The following is a description of a gene set: Mouse Gene Set: chr17E1 species: Mus musculus, and this is the list of marker genes: Togaram2, Myom1, Gm9311, Lpin2, Gm30091, Mettl4-ps1, Gm17228, Mir5709, Ypel5, Gm24730, Gm9319, Clip4, Gm49931, Lrrc30, Obox6-ps1, 5031415H12Rik, Lclat1, Gm16519, Gm26510, Gm49866, Pja2, Snord53, Gm22858, Efna5, Gm49894, Gm30420, Gm36252 (NCBI Gene Id 102640102), Gm9288, Lbh, Smchd1, Ndufv2, Akain1, Myl12b, Ptprm, Man2a1, Tmem232, Fbxl17, Lama1, Washc1, Spdya, Txndc2, Fer, 4930583I09Rik, Gm4512, Gm18992, Tmem200c, Gm18138, Gm36594, Gm49865, Gm9300, AU016765, Dlgap1, Dreh, 1600022D10Rik, Rab31, Mir6420, Wdr43, Snord92, 1700016K05Rik, Gm4701, Gm25406, Gm46576, Gm33890 (NCBI Gene Id 102636965), Gm35550, Gm5497, C030034I22Rik, Arhgap28, Gm4705, Gm18521, Gm19183, Gm18738, 4930471L23Rik, Gm49940, Gm6174, Twsg1, Gm49862, A930029G22Rik, Epb41l3, 4930405O22Rik, Gm25344, Myl12a, Gm17891, Gm18070, Alk, Ankrd12, Gm9598 (predicted gene 9598), L3mbtl4, Gm20742, Tgif1, Gm36201, Gm9984, Gm41611, Gm25800, Ndc80, Gm38593, Gm4566, Gm7253, Gm41609, Ralbp1, Gm17921, Gm49870, Ppp4r1, Rab12, Gm9320, Mtcl1, Gm18736, 2410021H03Rik, Zbtb14, Mir1195, Pcare (NCBI Gene Id 225004), Gm36487, Vapa, Trmt61b, Themis3, Gm4561, Emilin2, Gm15974, Gm26963, A730049N16Rik, Gm4518, Gm4707, Gm18961, Gm23447, Ddx11